Given this list of marker genes Rps5, Dcp1a, Lsm1, Pabpc1, Mir124a-1, Auh, Fxr2, Dppa5b, Xpo5, Nudt16, Nsrp1, A1cf, Fyttd1, Paip2, Rpl13a, Gnl3, Ncbp2 (nuclear cap binding protein subunit 2), mt-Th, Rpl35, Ddx21, Rps7, Strap, Alyreffm2, Cstf2, Unk, Tial1, Mrps7, Mir124a-2, Rps13, mt-Tl2, Rara, Tex13c3, Ddx20, Eif3d, Nudt21, Ddx43, Mettl3, Exosc8, Ddx39b, Pum2, Dppa5a, Rps3, Alyreffm14, Ssb, Shmt1, N4bp1, Celf3 (CUGBP, Elav-like family member 3), Nanos1, Zc3h12b, Eif4a3l1, Pcbp3, Nxf7, Secisbp2l, Hsp90aa1, Pabpc6, Celf4, Cpeb1, Rbm15b, Rbm47, Mir124a-3, Ythdf2, Fxr1, Myh10, Hnrnpk, Khsrp, Alyreffm3, Aco1, Fus, Srsf3, Rc3h1, Alyreffm10, Khnyn, Larp4, Alyreffm6, Slpi, Rbmx, Ptbp3, Mir24-1, mt-Tt, Dhx33, Rc3h2, Rbms3, Nxf3, Hnrnpll, Rps3a1, Nova1, mt-Tg, D1Pas1, Apobec1, Myef2, mt-Tl1, Elavl4, Thoc2, Btg4, Tex13c1, mt-Tw, Stau1, Dcp1b, Igf2bp3, Taco1, Larp6, Mir874, Hnrnpa3, Zfp385a, Ncl, mt-Tq, Mir23a, Rpl26, Nelfe, Jrk, Eef1a1, Casc3, Mir294, Lsm8, Piwil2, G3bp1, Alyref, Nynrin, Ythdf1, Hnrnpa2b1, Zfp36, Aqr, Nhp2, Sf3b6, Snip1, Rpl6, Sf3b1, Dhfr, Piwil1, Zfp36l1, Rbm42, Celf2, Spen, Pabpc5, Khdrbs2, Tdrd7 (tudor domain containing 7), Sugp1, Utp23, Pum1, Mbd2, Rnf20, Eefsec, Eif4e, Ppie, Scaf8, Ptbp1, Mir7116, Rbm14 (RNA binding motif protein 14), Ddx3x, Ddx23, Slc4a1ap, Secisbp2, Tardbp, Zcchc13, Cryz, Snrnp70, Hnrnpd, Trp53 (transformation related protein 53), G3bp2 (NCBI Gene Id 319444), Mirlet7g, Peg10, Rbfox3, Cpeb3, mt-Ts1, Ddx41, Cdc40, Nxf1, Mir21b, Cirbp (cold inducible RNA binding protein), Rpl7, Angel2, Ddx17, Arid5a, Celf1, Eif4a3, Gemin5, Atxn2, Lin28a, Srrm4, Mex3d (NCBI Gene Id 237400), Ncbp1, Cstf3, Ago2, Upf3a, Igf2bp1, Igf2bp2, Nicol1, Carhsp1, Ncbp3, Mir466l, Cnbp, Eif4g3, Cpsf6, mt-Ti, Stau2, Luc7l, Rbm8a, Ybx3, Rps26, Cct5, Mir1896, Hnrnpa1, Eif4a3l2, Rbms2, Zc3h12a, Larp1, Ybx2, Rbm15, Rnf40, Srsf7, Dnd1, Celf6, Nkap, Srsf4, Fubp1, Rbm20, Rbpms, Tsn, Mir24-2, mt-Tv, Rbmxl1, Cluh, Sf1, Exosc9, Rpl24, Mrpl12, Hnrnpl, Nanos3, Esrp1, Rbfox2, Mecp2, Angel1, Zc3h12c (NCBI Gene Id 330940), Atxn2l, Snrnp35, Gpatch8, Srsf6, Srsf1, Pcbp4, Hdlbp, Rsl1d1, Ythdc1, Pkm, Tyms (NCBI Gene Id 22171), Slirp, mt-Tm, Rps14, Copa, Thoc2l, Ddx19a, Zar1, Ilf3, Srrm2, Rps2, Csdc2, Rbm24, Hnrnpa0, Celf5, Tex13d, Pum3, Alyref2, Eif4g2, Pabpc2, Rbm46, mt-Tp, Khdrbs1, Rbm8a2, Arc, Tra2b, Luc7l3, Pcbp1, Mir9-1, Mvk, Fech, Lrpprc, Qki, Ddx59, Fmr1, mt-Tc, Taf15, Esrp2, Rbm38, mt-Tr, Rbm5, Mir186, Zar1l, Luc7l2, Thoc5, Slbp, Exosc4, Pcf11, Eif4enif1, Rbm25, Pabpc4, Mir409, Pabpc1l, Elavl1, Eif2s2, Lsm14b, Dxo, Zc3h12d, Boll, Nup98, Tex13a, Rbm44, Mir124-2hg, Msi1, Cstf2t, Dazl, Ddx19b, Hnrnpm, mt-Tn, Cpsf1, Nanos2, mt-Tk (NCBI Gene Id 17734), Eif4g1, Rps6, Ppp1r8, Pcbp2, Samd4 (sterile alpha motif domain containing 4), Purb, Ptbp2, Rbm4, Mir21c, mt-Ta, Exosc7, Msi2 (musashi RNA-binding protein 2), Hnrnpr, Alyreffm1, Rbfox1, Zfp638 (NCBI Gene Id 18139), Khdrbs3, Upf3b, Supt5, Larp4b, Rpl30, mt-Ts2, Ddx4, Hnrnpu, Ddx39a (NCBI Gene Id 68278), Ddx50, Ybx1, Fubp3, Srbd1, Snrpc, Mir21a, Ddx5, Rbpms2, Tia1, C1qbp, Syncrip, Lin28b, Hnrnpc, Rps6-ps4 (ribosomal protein S6, pseudogene 4), Dhx9, Ythdf3, Alyreffm5, Mir135a-1, Elavl3, Caprin1, Ddx6, Pabpc4l, Rbms1, Dazap1, Tut1, Grsf1 (NCBI Gene Id 97246), Rnps1, mt-Ty, Zfp36l2, Cpsf7, Serbp1, Zfp36l3, Noct, Eif4e2, Samd4b, Poldip3, mt-Te, Park7, Mettl14, Edc3, Rpl5, Mrpl13, Mir505, mt-Tf, Ddx25 (DEAD box helicase 25), Nxf2, Tpr, Etf1, Srrm3, Cpeb2, Ddx3y, Shfl (shiftless antiviral inhibitor of ribosomal frameshifting), Nova2, Ireb2, Alyreffm4, Dhx36, Eif3a, Calr, Cpeb4, Lsm14a, mt-Td, Rida, Eif2a, here is a description of the gene set: Mouse Gene Set: GOMF_MRNA_BINDING Binding to messenger RNA (mRNA), an intermediate molecule between DNA and protein. mRNA includes UTR and coding sequences, but does not contain introns. species: Mus musculus